Given this list of marker genes GP1BB, SLC37A4, F8, ITGA2B, GP6, FOXP2, IKZF5, BRCA2, EPHB2, NBEAL2, GP1BA, VWF, GP9, THBS2, DIS3L2, GPC3, TRIP13, REST, H19, POU6F2, TRIM28, ITGB3, WT1, here is a description of the gene set: Abnormality of von Willebrand factor Decreased quantity or activity of von Willebrand factor. Von Willebrand factor mediates the adhesion of platelets to the collagen exposed on endothelial cell surfaces. Human Gene Set: HP_ABNORMALITY_OF_VON_WILLEBRAND_FACTOR studied in species Homo sapiens